Given this list of marker genes Calm3, Calm2, Slc4a3, Atp2a2, Scn3b, Slmap, Kcnj2, Ank3, Flna (filamin, alpha), Fgf13, Tbx18, Ank2 (ankyrin 2, brain), Nup155, Dmd, Kcne3, Cacna1c, Dsg2, Snta1, Scn1b, Cacnb2, Dsp, Scn5a, Kcnq1, Hcn4, Tmem161b (transmembrane protein 161B), Kcna5, Ryr2, Calm1 (NCBI Gene Id 12313), Rnf207, Scn1a, Kcnh6, Kcnd2, Dsc2, Gpd1l, Dlg1, Kcnh2, Scn4b, Camk2d, Cav1, Nedd4l, Cacna2d1, Rangrf, Jup (NCBI Gene Id 16480), Trpm4 (NCBI Gene Id 68667), Kcne1, Kcnn2, Ctnna3, Cacna1d, Cav3, Cxadr, Kcnj5, Pkp2, Kcnj8, Kcne4, Gja5, Scn2b, Kcne5, Kcne2, Scn10a (NCBI Gene Id 208230), Akap9, Kcnd3, Bin1, here is a description of the gene set: An action potential that occurs in a cardiac muscle cell. Mouse Gene Set: GOBP_CARDIAC_MUSCLE_CELL_ACTION_POTENTIAL studied in species Mus musculus